Given this list of marker genes Tsc22d3, Gpam, Tnfsf4, Tnfrsf4, Fadd, here is a description of the gene set: studied in species Mus musculus Mouse Gene Set: GOBP_NEGATIVE_REGULATION_OF_ACTIVATION_INDUCED_CELL_DEATH_OF_T_CELLS Any process that stops, prevents, or reduces the frequency, rate or extent of activation-induced cell death of T cells.